The following is a description of a gene set: Human Gene Set: GOCC_CELL_POLE species: Homo sapiens Either of two different areas at opposite ends of an axis of a cell., and this is the list of marker genes: SLC3A2, DES, RDX, VANGL2, PI4K2A, ASTN2, RAB8B, SLC32A1, LRIT3, GRM6, PKP2, GNB5, RGS7